Given this list of marker genes Inpp5e, here is a description of the gene set: This event has been computationally inferred from an event that has been demonstrated in another species.<p>The inference is based on the homology mapping from PANTHER. Briefly, reactions for which all involved PhysicalEntities (in input, output and catalyst) have a mapped orthologue/paralogue (for complexes at least 75% of components must have a mapping) are inferred to the other species. electronically inferred by orthology from the curated human pathway part of: Cargo trafficking to the periciliary membrane studied in species Mus musculus Reactome Pathway: ARL13B-mediated ciliary trafficking of INPP5E